Given this list of marker genes Star, Bbs2, Ccna2, Pten, Lep, Mkks, Lepr, Fgb, Nr4a3, Edn1, Adipor1, Ugcg, Gck, Lrp2, Prmt2, Ccnd1, Acbd7, Nr1d1, Bbs4, Pid1, Sirt1 (NCBI Gene Id 93759), Stat3, Mt3 (metallothionein 3), Fgf23, Inhbb, here is a description of the gene set: studied in species Mus musculus Mouse Gene Set: GOBP_RESPONSE_TO_LEPTIN Any process that results in a change in state or activity of a cell or an organism (in terms of movement, secretion, enzyme production, gene expression, etc.) as a result of a leptin stimulus. Leptin is a hormone manufactured primarily in the adipocytes of white adipose tissue, and the level of circulating leptin is directly proportional to the total amount of fat in the body. It plays a key role in regulating energy intake and energy expenditure, including appetite and metabolism].